The following is a description of a gene set: Retaining the established polarization of a cell along its apical/basal axis. Mouse Gene Set: GOBP_MAINTENANCE_OF_APICAL_BASAL_CELL_POLARITY studied in species Mus musculus, and this is the list of marker genes: Wnt11, Crb2, Lhx2, Wdr1, Nherf1, Pdcd6ip, Llgl1